The following is a description of a gene set: species: Mus musculus Mouse Gene Set: GOBP_REGULATION_OF_JUN_KINASE_ACTIVITY Any process that modulates the frequency, rate or extent of JUN kinase activity., and this is the list of marker genes: Fzd5, Map3k4, Pdcd4, Dtnbp1, Rps3 (ribosomal protein S3), Fzd4, Dab2ip (NCBI Gene Id 98996), Fgd2, Traf2, Aida, Map2k7, Ccr7, Dnaja1, Map3k5, Dusp10, Nppa, Arhgef5, Mapk8ip1, Sash1, Ptpn22, Magi3, Ern2, Taok3, Ager, Vangl2, Gstp2, Sfrp2, Pak1, Gstp1, Map3k13, Mapk8ip3, Tnfrsf11a, Syk, Ern1, Map3k11, Fgd4, Dvl2, Map3k7, Hipk3, Sfrp5, Tirap, Dusp19, Tnf, Map2k4, Fcer1a, Irak1, Gstp-ps, Zeb2, Gstp3, Map3k1, Map3k10, Ccl19, Wnt5a, Bcl10, Traf6, Fzd8, Epha4, Edn1, Tlr6, Map3k12, Ptpn1, Sfrp1, Axin1, Map4k2 (mitogen-activated protein kinase kinase kinase kinase 2)